Given this list of marker genes ACADM, CROT, ACOT7, CYP4A22, ABHD2, OLAH, GLYATL2, CES1, CYP4A11, CRAT, ABHD3, CYP4Z1, ABHD1, ACAD9, OXSM, here is a description of the gene set: studied in species Homo sapiens Human Gene Set: GOBP_MEDIUM_CHAIN_FATTY_ACID_METABOLIC_PROCESS The chemical reactions and pathways involving a medium-chain fatty acid. A medium-chain fatty acid has an aliphatic tail containing 6 to 12 carbons.